Given this list of marker genes SASH3, SMARCAL1, PIK3R1, IRF1, POLD3, here is a description of the gene set: Abnormal increase or decrease of the naive CD8+ T cell subpopulation, commonly characterized as CD45RA+, CD45RO-, or CD27+, measured as percentage of total CD8+ T cells in the blood, compared to a reference range for a given sex and age-group. These cells are sometimes also characterized as CD62L+ and CCR7+. species: Homo sapiens Abnormal naive CD8 T cell proportion Human Gene Set: HP_ABNORMAL_NAIVE_CD8_T_CELL_PROPORTION